Given this list of marker genes C3, ADIPOQ, MIR144, PRAP1, ABCA8, GHRL, P2RX4, XRCC4, TMF1, APOE, EHD1, ACSL5, PLA2G3, NKX3-1, ABCA3, TNFSF11 (TNF superfamily member 11), NR1H3, CD36, FASLG, PLTP, PLA2G10 (phospholipase A2 group X), ABCA13, OXT, PLA2R1, LDLRAP1 (low density lipoprotein receptor adaptor protein 1), TMEM30A, LRAT, APOA1, TNFRSF11A, PRELID1, ZC3H12A, ZDHHC8, C1QTNF1, LIPG, HILPDA, CRH, NMB, RXRA, PLIN5, ACACB, CYP4F2, MYB, APOB, ABCA7 (NCBI Gene Id 82843), SIRT1, PTGES, DENND5B, PTCH1, ABCB4, NFKB1, TAC1, ECRG4, TRIAP1, COMMD1, CETP, SCP2, IL1B, GPS2, PON1, RETN, PLA2G4A, EDN1, SREBF2, PLIN3, MIR206, BMP6, AVPR1B, DBI, CES1 (NCBI Gene Id 1067), MIR10B, SCARB1, EEPD1, ANXA2, ATP8A2 (ATPase phospholipid transporting 8A2), PPARG, PLIN2, GALR1, ABCA1, SPP1, NTSR1, GAL, LPL, APOC4, TREM2, ATP8A1, CYP19A1, VSTM2A, MIF, LPCAT3, ABCG1, ERFE, ACSL1, ABCA5, ANXA2P2, IKBKE, LRP1, NR1H2 (NCBI Gene Id 7376), CYP4A11, CAV1, ABCA12 (NCBI Gene Id 3392), MIR34A, FABP3, MSR1, ABCG4, P2RX7, DAB2, PRKCD, here is a description of the gene set: species: Homo sapiens Human Gene Set: GOBP_POSITIVE_REGULATION_OF_LIPID_LOCALIZATION Any process that activates or increases the frequency, rate or extent of lipid localization.